Given this list of marker genes Chd7, Bak1, Lrp2, Fgf10, Stra6, Mertk, Npr2, Bax, Tyro3, Esr1, Axl, Lhx1, Rbp4, Srd5a2, Wnt5a, Esr2, Tbx3, Trp63, Cyp19a1, here is a description of the gene set: The process whose specific outcome is the progression of the female genitalia over time, from formation to the mature structure. species: Mus musculus Mouse Gene Set: GOBP_FEMALE_GENITALIA_DEVELOPMENT